Given this list of marker genes REV1, POLDIP2, POLD1, POLH, RCHY1, here is a description of the gene set: Human Gene Set: GOBP_ERROR_FREE_TRANSLESION_SYNTHESIS studied in species Homo sapiens The conversion of DNA-damage induced single-stranded gaps into large molecular weight DNA after replication by using a specialized DNA polymerase or replication complex to insert a defined nucleotide across the lesion. This process does not remove the replication-blocking lesions but does not causes an increase in the endogenous mutation level. For S. cerevisiae, RAD30 encodes DNA polymerase eta, which incorporates two adenines. When incorporated across a thymine-thymine dimer, it does not increase the endogenous mutation level.